The following is a description of a gene set: Transport of Mature mRNAs Derived from Intronless Transcripts Mouse Gene Set: REACTOME_TRANSPORT_OF_MATURE_MRNAS_DERIVED_FROM_INTRONLESS_TRANSCRIPTS studied in species Mus musculus, and this is the list of marker genes: Nup188, Fip1l1, Nup93, Slbp, Nup210, Ndc1, Nup160, Nup37, Sec13, Nup54, Rae1, Nup98, Eif4e, Seh1l, Ranbp2, Tpr, Nup88, Nxf1, Ncbp1, Alyref, Nup214, Nup107, Pom121, Nup153, Cpsf4, Nup43, Cpsf1, Nup133, Nup62, Ncbp2, Nup58, Nup35, Cpsf2, Nup50, Nup155, Nup85, Cpsf3, Nup42, Sympk, Nup205, Aaas, Wdr33